The following is a description of a gene set: Proliferative changes of the bile ducts. studied in species Homo sapiens Bile duct proliferation Human Gene Set: HP_BILE_DUCT_PROLIFERATION, and this is the list of marker genes: TMEM67, POLG (DNA polymerase gamma, catalytic subunit), MICOS13, ABCB4, KIF12, DCDC2, TMEM216, NPHP3, CEP290, WDR35, FARSB, IFT56, PHKG2, MED12, RPGRIP1L, CC2D2A, SLC37A4, CLDN1, MKS1, CYP7B1, HSD17B4